The following is a description of a gene set: Genes down-regulated in naïve untreated macrophages versus tolerant macrophages stimulated by LPS. from publication Mages J, Dietrich H, Lang R (PMID 18086374) Among the multiple mechanisms that control the intensity and duration of macrophage activation, the development of a state of refractoriness to a second stimulation in cells treated with LPS has long been recognized. Release of inhibitory cytokines and alterations in intracellular signaling pathways may be involved in the development of LPS tolerance. Although a number of molecules have been implicated, a detailed picture of the molecular changes in LPS tolerance is still missing. We have used a genome-wide gene expression analysis approach to (i) define which fraction of LPS target genes are subject to tolerance induction and (ii) identify genes that are expressed at high levels in tolerant macrophages. Our data show that in LPS tolerant macrophages the vast majority of LPS-induced gene expression is abrogated. The extent of tolerance induction varies for individual genes, and a small subset appears to be excepted. Compared to other negative control mechanisms of macrophages, e.g. IL-10-induced deactivation, LPS-tolerance inhibits a much wider range of transcriptional targets. Some previously described negative regulators of TLR-signaling (e.g. IRAK-M) were confirmed as expressed at higher levels in LPS-tolerant macrophages. In addition, we discuss other potential players in LPS tolerance identified in this group of genes. Human Gene Set: GSE8621_UNSTIM_VS_LPS_PRIMED_AND_LPS_STIM_MACROPHAGE_DN species: Homo sapiens, and this is the list of marker genes: CHCHD10, GRAP, KLRG1, RNF169, URI1, TMEM108, SLCO4A1, IWS1, PRSS54, PPARD (peroxisome proliferator activated receptor delta), ARF3, USP7, ATP8B4, BCL2, CASS4, MEF2D, DHX33 (DEAH-box helicase 33), ZNF679, DUSP7, C1QBP, DYNC2H1, WDFY4, NMRK2, ABTB3, MED1, CHFR, FAM120AOS, AKNA, BMPR1A, DNTT, TMEM268, LGI3 (leucine rich repeat LGI family member 3), UBE4B, CREBBP, MTMR4, PALD1, ATP7A, MAP3K5, ZNF250, CISH, AFF3, HDAC9, COL19A1, STK10, IGLL1, AACS, KCTD5, PAN3, MGST2, HMGCS1, PDE2A, INTS6, USP42, TET1, BLTP3A, ENTPD7, RC3H1, RHOQ, TRIM25, ESR1, FOXO1, IGHM, ASXL1, ABHD2, PLEKHA7, SLC29A3, PLEKHA2, LPAR2, MED13L, CDH23, CRYBG3, PRKCB, ENC1, RBP2, CACNB1, SHMT1, LY6D, TP53INP1, UPF3A, XPO7, CCDC93, MAP3K1, HGH1, GTF2A1L, TENT4B, FAM8A1, SLC15A3, OPA1, CAMK1D, BIRC6, SLC35D3, TCN2, PRR14L, RAD18, PIP4K2A, IKZF1, TRAF3IP2, HMGA2, HARS1, CYB561A3, TBXA2R, TRIM65 (tripartite motif containing 65), PTGDR2, PREX1, CERS6, NOTCH1, EPB41L4B, SH2D5, SLC38A2, TMEM109, APCDD1, OAZ3, SATB1, PGR, TCF19, HCN1, CHST15, S1PR3 (NCBI Gene Id 414320), PRR36, PHACTR4, ENDOU, DYRK2, MN1, TMEM170B, SLFN13, IP6K2, AP2A2, PAK2, HLA-DOB, GPR25, ITPR1, BANK1, PCP4, GMEB1, GPSM1, OSR2, ACLY, KIF17, CTU2, PLCL1, ADGRG3, HOXD9, ALKBH5, SPHK1 (sphingosine kinase 1), CDK19, TBL2, POMGNT2, RBM10, SAPCD1, HSPH1, SLC38A1, TBC1D16, MSL1, IPCEF1, TRIP11, ZGRF1, WASL, SETD4, ATXN2, SRRM2, TNFAIP1, WDHD1, RAB43, PRKCA, PDE3B, TCF4, CNP, SLC27A2, IRF8, SEC61A1, CBX4, IL7R, TMEM131, ANKLE2, GIMAP7, BMP2K, SHARPIN, PIK3AP1, CD33, TXNIP, ANKRD26, ABI2, DCTN4, CHRNA2, TNRC6A, SRRM1, GTF3C4, CNN3, PARP1 (NCBI Gene Id 142), SCAP, IL18R1, CDS1, TIAM1, HSD17B7, CNTD1, KBTBD11, NUCB2, PAOX, JDP2 (NCBI Gene Id 122953)